The following is a description of a gene set: Systems vaccinology has emerged as an interdisciplinary field that combines systems wide measurements and network and predictive modeling applied to vaccinology. Here we used the systems vaccinology approach to study the molecular mechanisms underlying th from publication Nakaya HI, Wrammert J, Lee EK, Racioppi L, Marie-Kunze S, Haining WN, Means AR, Kasturi SP, Khan N, Li GM, McCausland M, Kanchan V, Kokko KE, Li S, Elbein R, Mehta AK, Aderem A, Subbarao K, Ahmed R, Pulendran B (PMID 21743478) studied in species Homo sapiens Human Gene Set: GSE29618_MONOCYTE_VS_PDC_DAY7_FLU_VACCINE_DN Genes down-regulated in comparison of monocytes from influenza vaccinee at day 7 post-vaccination versus plasmacytoid dendritic cells (mDC) at day 7 post-vaccination., and this is the list of marker genes: DUSP5, CBX5, KCNA5, MREG, NPC1, KIF5B, TCL1A, TRIT1, SEC61B, DSTN, MYB, PPIB, RHOH, AQP3 (aquaporin 3 (Gill blood group)), H2BC10, MZB1, APP, AMIGO2, MDFIC, NRP1, HLTF, ZHX2 (zinc fingers and homeoboxes 2), IGKC, TRAF4, RUBCN, MAPKAPK2, PHEX, RAB15, DACH1, PCNT, NUCB2, BLNK, PEBP1, MGAT4A, PACS2 (NCBI Gene Id 23241), SMC6, H1-3, SIDT1, CSF2RB, FCHSD2, PTPRCAP, SEPTIN6, GAS6, PARK7, CYFIP2, MAP1A, NREP, CCDC186, SEC61A2, SEC61G, ADA, GTF2I, RBBP7, GRAMD1B, LZTFL1, RUNX2, ANKRD12, DNAJC4, LY9, MAP2K6, PTGDS, PMS2P2, POLB, DDX24, TCF4, ST3GAL2, COBLL1, DDX17, TRAM1, STMN1, IGHM, SPCS1, ITCH, IL3RA, MAGED1, BCL7A, DPP4, LAMP5, FHL1, FKBP11, SCN9A, DAB2, GLO1, SLC7A5, IL18R1, HIGD1A, HHAT, RPS20, LILRA4, ALOX5AP, CRIM1, UBE2J1, ADAM19 (ADAM metallopeptidase domain 19), TCF3, PIK3CG, AFF3 (NCBI Gene Id 3899), SINHCAF, FLNB, KCNK10, SPCS3, TSPAN3, BBIP1, CUX2, CERS6, USP24 (ubiquitin specific peptidase 24), OGT, ZNF22, PPP1R16B, ZDHHC4, FKBP2, CLN8, OPN3, SLC38A1, LGMN, DACT1, BCL11A, GPM6B, RGS7, TMEM109, SEL1L3, SIGLEC6, GNG7, ANKRD36, REPIN1, NDRG1, LILRB4, PHACTR1, TMED10, AHNAK2, PPP1R14B, AUTS2, TM9SF2, SPIB, PDIA4, MYO9A, HINT1, ODC1 (ornithine decarboxylase 1), TMED3, SLC7A11, CUEDC1, OBSL1, SSR4 (NCBI Gene Id 6748), MAPRE2, TMED2 (NCBI Gene Id 10959), AHI1, CD164, H2BC8, TMEM8B, CCDC88A, PMS2P5, ATP2A3, TBC1D4, AEBP1 (NCBI Gene Id 165), ANKRD36B, SNRNP25, IRF8, ST6GALNAC4, SLC2A1, EPHB1, GUCY1A1, ZEB1, NOTCH4, UGCG, CD2AP, NGLY1, PAFAH2, CUL4B, MTMR1, GGA2, TEX2, B4GALT1, ATP8A1, RRBP1, SETBP1, SPINT2 (serine peptidase inhibitor, Kunitz type 2), DNASE1L3, ZDHHC17, MAP4K1, H2BC7, IDH3A, SCAMP5, TPM2, DCK, ITM2C, IRF4, RPSA, LBH, PTPRS, RIOX2, HSP90B1 (heat shock protein 90 beta family member 1), CCNYL7, TMEM14A, ZNF589, GOLGA8A, SCT, INPP4A, SRP14, OFD1, MDN1